Given this list of marker genes Prrc2b, Cd37, Osbpl3, Ptpre, Akap13, Xrn1, Ypel3, Arhgef1, Smc4, Ech1, Gmfg (NCBI Gene Id 80485), Cd2, Hsd11b1, Cyb5a, Kmt2c, Cd3d, Ighm, Dpm3 (dolichyl-phosphate mannosyltransferase polypeptide 3), Cnot6l, Avl9, Arid4a, Jun, Ubc, Atp6v1d, Crot, Trgc1, Lat, Coro2a, Rab37, Flt3l, Crip1, Dnaja1, Trbc2, Rassf2, Pycard, Tespa1, Ms4a4b, Hspa1a, Paip2, S100a4, Nsg2, Samhd1, Tecr, Cd27, Klf4 (NCBI Gene Id 269540), Tln1, Tbc1d10c, Kmt2e, Ahnak, Acyp1, Arl4c, Emp3, Samd9l, Arf5, AI467606, Ltb, Sdc1, Septin1 (NCBI Gene Id 54204), Fxyd5, Clic1, Srpk2, Psap, Ptpra, Prr13, Atraid, Ski, Kif21b, Timp2, Hspa1b, S100a13, Igf1r, Acap1, Rnf166, Rasgrp2 (NCBI Gene Id 386467), Zyx, Tmem256, Acaa2, Ipcef1, Rinl, Zfp36, Rgs10, Rnf167, Podnl1, Ctsw, Cxcr6, Med28, Lbh, Rhob, Hcst, Tgfbr2, Cyth4, Mpst, Cotl1, Dusp1, Npc2, Aak1, Stk24, Evl, Tax1bp1, Stap1, Evi2a, H3f3b, Neat1, Rarg, Stk17b, Ar, Itm2b, Cers4, Rcbtb2, Wbp1, Sh3bgrl3, Tmem50a, S100a6, Epsti1, Bscl2, Jaml, Chd3, Jund, R3hdm4, Rabac1, Lpar6, Sit1, Cd52, Il18r1, Lamtor4, Arhgdib, Macf1, Tspan32, Pkn1 (protein kinase N1), Ikzf2, Mxd4, Esyt1, Coq10b (NCBI Gene Id 98730), Irf2bpl, Ripor2, Tmsb10, Pcbd2, Sh3kbp1, Klrk1, Cox7a2l, Anxa1, Ifi203, Aqp3, Slc12a7, Itgae, Syne1, Qpct, Lck, Klf6 (Kruppel-like transcription factor 6), Rhoh, Cox20, 9930111J21Rik2 (NCBI Gene Id 245240), Tesc, Kdm7a (lysine (K)-specific demethylase 7A), Runx1, Ltb4r1, Gpr183, Fosb (NCBI Gene Id 14282), Gsk3b, AI504432, Mgst2, Oxct1, Dapp1, Thy1, Ccnd2, Btg2, Rnf144a, Lamtor2 (NCBI Gene Id 83409), Fam83a, Bin1, Tle4, Ckb (creatine kinase, brain), Il17re, Add1, Clint1, Eeig1, Lmo4, Gpbp1l1, Plin3, Mllt3, Gnai2, Top2b, Chd2, Rasgrp1, Ankrd44, H1f2, Dctn1, Ddx5, Lsp1, Apbb1ip, Septin7, Lncpint, Vim, Tmco1, Ramp1, Plp2, Ptprcap, Arhgap45, Ctsd, Actn2, Leprotl1 (NCBI Gene Id 68855), Wls, Dusp5, Ppp1r12a, Ppp1r18, Cnp, Ppp1ca (protein phosphatase 1 catalytic subunit alpha), Pkp3, Plgrkt, Cd48, Fkbp3, Ccr2, Arid1a, Itpkb, Atp2a3, Capn2, Selplg, Arl5c, Gng2, Arrb1, Cmtm7, Tnrc6b, S100a10, Sema4a, Mtss1, Foxp1, Lgals1, Smpdl3a, Lysmd2, Selenop, Il7r, Slc25a4, Reep5, Uba52, Bnip3l, Eif4e3 (eukaryotic translation initiation factor 4E member 3), Saraf, Cdkn1b, Nes (NCBI Gene Id 97066), Pstpip1, Cd7, H2az2, Adgre5, Cd3e, Cmc2, Rasa3, Tmem64, Anxa6, Ppp3ca, Plec, Trac, Man2a2, Eid1 (NCBI Gene Id 66519), Dock2, Adcy7, Ebpl, Tle5, Scamp3, Ctps2, Mapre2, Cd28, Ms4a6b, Cd47, Il17rb, Abca2, Sla, Shisa5, Itgb7, Ncor1, Skap1, Prkacb, Stim1, Klf2, Dap, Cd3g, Scp2, Kcnk1, Itgal, Ier2, Ndufv3, H1f4, Crtc3, Asxl2, Dexi, Themis, Klhl24, Serpinb1a, Capg (capping actin protein, gelsolin like), Bin2, Esyt2, St3gal6, Cdc42ep3, Rexo2, Faah, Bcl11b, Mndal, Trbc1, Lonp2, Hp1bp3, Elf1, Tmem126a, Ucp2, Gm2a, Pag1, Egr1 (NCBI Gene Id 13653), Acsbg1, Crlf3, Cmtm6, Rgcc, Mbd2, Clec2d, Hadh, Tsc22d4, Slfn5, Taok1, Cd96, F2r, Junb, B3gat3, H2-Q4, Dgka, Gpsm3, Gnb2, Antkmt, Icos, Crebrf (NCBI Gene Id 77128), S100a11, Nt5e, Paxx, Orai2, Coro1a, Tnik (NCBI Gene Id 99639), Tspo, Sp100, Kcnn4, Fos, Msi2, Lbr, Cited2, Myh9, Atp2b1, Mbnl1, Anapc11, Flna, Ptpn18 (protein tyrosine phosphatase, non-receptor type 18), Cast, here is a description of the gene set: Cytokines mediate cell-cell communication in the immune system and represent important therapeutic targets. A myriad of studies have highlighted their central role in immune function, yet we lack a global view of the cellular responses of each immune cell type to each cytokine. To address this gap, the authors created the Immune Dictionary, a compendium of single-cell transcriptomic profiles of more than 17 immune cell types in response to each of 86 cytokines (>1,400 cytokine-cell type combinations) in mouse lymph nodes in vivo. A cytokine-centric view of the dictionary revealed that most cytokines induce highly cell-type-specific responses. For example, the inflammatory cytokine interleukin-1β induces distinct gene programmes in almost every cell type. A cell-type-centric view of the dictionary identified more than 66 cytokine-driven cellular polarization states across immune cell types, including previously uncharacterized states such as an interleukin-18-induced polyfunctional natural killer cell state. Mouse Gene Set: CUI_T_CELL_GD_IL1B_RESPONSE_DN from publication Cui A, Huang T, Li S, Ma A, Pérez JL, Sander C, Keskin DB, Wu CJ, Fraenkel E, Hacohen N (PMID 38057668) studied in species Mus musculus Genes negatively differentially expressed in cell type: γδ T cell upon treatment with cytokine: IL-1β in mouse lymph nodes in vivo.